The following is a description of a gene set: species: Mus musculus Mouse Gene Set: GOBP_CHEMOREPULSION_OF_AXON The process in which a neuron growth cone is directed to a specific target site in response to a repulsive chemical cue., and this is the list of marker genes: Plxna4, Unc5c, Ntn1, Wnt5a, Ryk